The following is a description of a gene set: studied in species Mus musculus The removal of palymitoyl groups from a lipoprotein. Mouse Gene Set: GOBP_PROTEIN_DEPALMITOYLATION, and this is the list of marker genes: Ppt1, Lypla1, Lypla2, Abhd13, Lyplal1, Abhd10, Abhd12, Abhd17b, Abhd17c, Abhd17a